Given this list of marker genes PCSK5 (proprotein convertase subtilisin/kexin type 5), FKBP4, GRN, SMAD3, AGO2, SOD1, ERRFI1, MMP2, CALR, TPPP3, ACVR1B, PTGS2, VEGFA, LAMB1, PRLR, SYDE1, FBN2, EPO, IL1B, STC2, YTHDF3, MIR16-1, MMP9, STC1 (stanniocalcin 1), SMAD2, POLR1B, INTS1, APLF, H3-3A, MIR15B, PTGIS, ACVR2B, A1CF, SCGB1A1, TGFBR1, PRDM14, APELA, DDR1, HMX3, TIMP1, BSG, MSTN, ARHGDIB, RPL29, FUT7, MIR21, ACVR1C, IGFBP7, ACOD1, EMP2, RECK, ITGB3 (integrin subunit beta 3), TRIM28, IL11RA, SPP1, PPARD, LIF, CALCA, SMURF2, NODAL, TEAD4, ITGB4, TRO, VMP1, GJA1, C1QBP, FBLN1, UBTFL1, UBE2Q1, H3-3B, HSPG2, here is a description of the gene set: Attachment of the blastocyst to the uterine lining. Human Gene Set: GOBP_EMBRYO_IMPLANTATION species: Homo sapiens